Given this list of marker genes Ripk2 (receptor (TNFRSF)-interacting serine-threonine kinase 2), Irak1, Trem2, Tlr2, Nod2, Inava, Myd88, C5ar1 (NCBI Gene Id 12273), Camp (NCBI Gene Id 12796), Irf5, Card9, Defb25, Irak3, Rela, Nlrp3, here is a description of the gene set: Any process that results in a change in state or activity of an organism (in terms of movement, secretion, enzyme production, gene expression, etc.) as a result of a peptidoglycan stimulus. Peptidoglycan is a bacterial cell wall macromolecule. species: Mus musculus Mouse Gene Set: GOBP_RESPONSE_TO_PEPTIDOGLYCAN